The following is a description of a gene set: from publication Aiyar SE, Blair AL, Hopkinson DA, Bekiranov S, Li R (PMID 17043641) Genes down-regulated in T47D cells (breast cancer) after COBRA1 knockdown by RNAi. Human Gene Set: AIYAR_COBRA1_TARGETS_DN Eucaryotic genes that are coordinately expressed tend to be clustered. Furthermore, gene clusters across chromosomal regions are often upregulated in various tumors. However, relatively little is known about how gene clusters are coordinately expressed in physiological or pathological conditions. Cofactor of BRCA1 (COBRA1), a subunit of the human negative elongation factor, has been shown to repress estrogen-stimulated transcription of trefoil factor 1 (TFF1 or pS2) by stalling RNA polymerase II. Here, we carried out a genome-wide study to identify additional physiological target genes of COBRA1 in breast cancer cells. The study identified a total of genes that were either activated or repressed upon small hairpin RNA-mediated reduction of COBRA1. Interestingly, many COBRA1-regulated genes reside as clusters on the chromosomes and have been previously implicated in cancer development. Detailed examination of two such clusters on chromosome 21 (21q22) and chromosome X (Xp11) reveals that COBRA1 is physically associated with a subset of its regulated genes in each cluster. In addition, COBRA1 was shown to regulate both estrogen-dependent and -independent transcription of the gene cluster at 21q22, which encompasses the previously identified COBRA1-regulated TFF1 (pS2) locus. Thus, COBRA1 plays a critical role in the regulation of clustered gene expression at preferred chromosomal domains in breast cancer cells. studied in species Homo sapiens, and this is the list of marker genes: SPINK5, NELFB, HPRT1 (NCBI Gene Id 3251), PSMD12, TMT1A, CPD, ZNF532, GOT2, AAGAB, PCP4, LINC00581, FGFR3, CLDN4, DCTN2, HNRNPAB, KITLG, HELLS, MYO5C, PRX, HSPB1, MCM2, EPHB3, SOX4, SRSF2, SLC20A1, APIP, PHYKPL, BAG1, PRDX3, ZNF395, DCPS